Given this list of marker genes DLEU7, COBLL1, GCNT2, ALPK3, GTSF1, NBEA, TNP1, REST, BACH2, GTF2E1, RER1, XAGE1B, LRIG3, AFDN, OSTF1, SV2C, TLR2, HYCC2, FAM171A1, RAB3C, STOX2, UBE2G1, ARMC1, MRGBP, WASL, BTBD7, PLXNA2, FBXO33, PDE6A, PLPPR1, RIOK3, AGAP1, N4BP2L1, LEPROTL1, GAN, BCORL1, COL13A1, CHST15, PPP1R9B, WRNIP1 (WRN helicase interacting protein 1), ACKR3, BRWD3, SF3B1, PLXDC2, DKK2, YY1, SLC25A4, SC5D, ARHGEF38, ZNF512B, USP16, EGLN1, MYBL1, KRT32, PHACTR2, BTBD1, MUSTN1, MGAM, TAFA3, FOXJ3, SND1, STIMATE-MUSTN1, SLC38A2, JMJD1C, SHOC2, DNAJC24, ANP32E, ABRAXAS2, CDC26, KRT74, LSM8, PIK3R1, EBAG9, CDX2, CREBRF, DPY19L2, VANGL1, ISX, SDK2, BNIP1, NF1, ERICH3, L3HYPDH, MAP2, NKAIN2, PPFIBP1, STARD13, GPAT3, here is a description of the gene set: from publication Chen Y, Wang X (PMID 31504780) studied in species Homo sapiens Human Gene Set: MIR4799_3P Genes predicted to be targets of miRBase v22 microRNA hsa-miR-4799-3p in miRDB v6.0 with MirTarget v4 prediction scores > 80 (high confidence targets).